The following is a description of a gene set: species: Homo sapiens A functional abnormality of a white blood cell. Abnormal leukocyte physiology Human Gene Set: HP_ABNORMAL_LEUKOCYTE_PHYSIOLOGY, and this is the list of marker genes: IPO8, RAG2, GPC3, UHRF1, RASGRP1, PIGT, SP110, DGCR2, TERT, FLII, GP1BB, RTEL1, NCKAP1L, MTHFD1, CASP8, IL12RB1, RFXANK, ESS2, SLF2, RNF113A, CARD11, NLRC4, DOCK11, KRT5 (keratin 5), STIM1, GBA1 (NCBI Gene Id 82008), PMM2, CCNO, KLHDC8B (NCBI Gene Id 200942, kelch domain containing 8B), CR2, PGM3, BLM, HYOU1, STAT1 (signal transducer and activator of transcription 1), PSTPIP1, MAGT1, ERCC3, SRP54, TBX1, CBLB, STAT5B, CISD2, SIK3, LEP, PSMB4, ARHGEF1, TP53, FNIP1, TNFRSF1B, CD55 (CD55 molecule (Cromer blood group)), BTK, TYK2, PSMB8, PIK3CG, SPIB, DGCR6, IQSEC2, SLC35C1 (solute carrier family 35 member C1), IVNS1ABP, PIK3R1, XIAP, LCP2, GTF2H5, B2M, DOCK2, TFRC, COL7A1, SFTPC, NFKB1, MYD88, POU2AF1, IL2RB, DNAJC21 (NCBI Gene Id 134218), EPG5, HLA-DQB1, LEPR, MRTFA, MUC5B, DRG1, STX11, STAT3, ZEB2, MALT1, IRF2BP2, CAVIN1, SPPL2A, TNFRSF9, CCND1, LMNA, CD70, TRNT1, RBM8A, ITCH, NCF1, CSNK2A1, NLRP1, PTPRC, TYMS, TCF3, CD28, EXTL3, RNU4ATAC, TNPO3, UFD1, ATM, AK2 (adenylate kinase 2), POLD3, GPR35, SH3KBP1 (SH3 domain containing kinase binding protein 1), IKBKB, IFIH1, CARD10 (caspase recruitment domain family member 10), WAS, PSMB9, MMEL1, LCK, KDM6A, AICDA, LRBA, CD3G, PDCD1, CD40, NSD2, KRT9, PRKCD, RPA1, LYN, HIRA, RFX5, IGLL1, SLC25A13, CPLX1, RAI1, OTULIN, CIITA, CD3D, SETX, ICOSLG, ATP6AP1, ERCC2, IL17RA, DCLRE1C, GATA3, KRT74, TPP2, MTOR, CD40LG, DOCK8, SEC61A1, EFL1, ARPC5, STING1, TNFSF15, IL2RG, BLNK, HLA-DRB1, IL6R, CTBP1, MSN, DEF6, GPI, FAT4, NHEJ1, SASH3, PLCG2, CYBB, AP3B1, TCF4, TNFRSF13C, IKZF1, CTNNBL1, ATP6AP2, TOM1 (NCBI Gene Id 10043), UMPS, POLE, GTF2E2, IL2RA, TRMU, KRAS, BCL10, TNFRSF11A, LIG4, CD3E, FCGR3A, AARS1, SPI1, SMARCAL1, PTEN, CTPS1, SEC24C, PNP (NCBI Gene Id 4860), RAD50, TARS1, RREB1, COG6, BACH2, IL6ST, CD81, LYST, RNF168, PLVAP (NCBI Gene Id 83483), RAC2, SEMA4D, MST1, TNFRSF13B, MOGS, NAE1, COMT, MAN2B1 (mannosidase alpha class 2B member 1), PIK3CD, ADAM17, LETM1, FLNA, CD79B, SLC19A1, SON, MS4A1, IRAK4, ADAMTS3, SHARPIN, SH2D1A, STXBP2, IL21R, LIG1 (DNA ligase 1), SYK, TIMM8A, VPS45, SLC39A7, NSMCE3, SLC7A7, NELFA, HELLS, DGCR8, SLC5A6, CORO1A, CD27, UNG, JAK3, SBDS, FOXN1, ZAP70, STAT2, CXCR4 (NCBI Gene Id 93405), STAT6, CARMIL2, CARS1, IL7R, ELANE, FASLG, CDSN, ITK, IRF1, KRT14, CYBA, CD247, NCF2, MVK, IL21, RMRP, RAG1, LAMTOR2, ICOS, SFTPA2, TTC7A, CNBP, ALB, CCBE1, IGHG2, MYSM1, MPLKIP, ARVCF, REL, SCARB2, MAP3K14, FAS, PIGG, FOXP3, CYBC1, ZNF341, POMP, NFKB2, CARD9, IFNGR1, ZBTB24, PRF1, TGFB1, EGFR, SAMD9L (NCBI Gene Id 4827), VPS33A, SPINK5, PSMB10, CD79A, MGAT2, IGHM, NRAS, SKIC2, NBN, POLD1, CASP10, CTLA4, TNFSF12, MCTS1, TLR8, UNC13D, MCM10, RFXAP, JMJD1C, PEPD, ORAI1, RIPK1, NFKBIA, DEAF1, KMT2D, SLC39A4, FBXL4, ADA2, ALG12, NFE2L2, IL12A, HLA-DQA1, SKIC3, IKBKG, IRF8, KNSTRN, DNMT3B, RAB27A, COL1A1, IRF5, ADA, LAT, GPC4, NHLRC2, WIPF1, TCN2, OAS1, TONSL, SLC46A1, LRRC8A, CEBPE, DSG1 (NCBI Gene Id 1828), RNF31, PRIM1, CDCA7 (cell division cycle associated 7), CD19, IGKC